Given this list of marker genes GPM6A, KRTAP13-2, ALDOC (NCBI Gene Id 230), FAM83H, HNRNPUL1, PRSS27, SRRM3, MNT, CEP95, EXOC5 (NCBI Gene Id 29024), RAVER1, TCERG1, PANX3, TFE3, MAG, GPRIN3, RAPGEFL1, QSOX1, SRSF6, LEP, NEUROG1, HOXA3, SPATA3, AMMECR1L, ERG, HOXA11, WNT10A, MDM4, NUDT4, SPAG9, DRG1, HNF4G, GON7, ZKSCAN8, DPP8, CELF2, CD40LG, TLN1, TOB1, KCNH2, GBX2, COL11A2, PCYT1B, FGF14 (fibroblast growth factor 14), HHEX, EFNA5, TFAP2E, ZNF276, RASAL2, CHGA, UBR7, SSC4D, YWHAE, LZTS2 (NCBI Gene Id 84445), KCNQ4, PAX6, SMAD6 (SMAD family member 6), SART1, MYH1, AP5M1, MOSPD1, PCGF2, TSSK2, DDX5, ANK3, COL11A1, ACY3, SELENOS, GADD45A, FBXL19, MAP2, DHRS11, ZNF654, HMGB1, RAB7A, ITGB4, ATG9A, PLXNB1, NFATC3, MYOZ2, PRKAG1, DIAPH1, SETD2, MIR17HG, CARMIL3, MAP4K5, RORB, TLX3, HPCA, POU4F3, SMTNL2, TSPAN17, MYF6, STC2 (NCBI Gene Id 8614), NXPH1, BCOR, HCN4, MORN1, FZD1, EIF4G2, TEKT5, ASIC5, FEZF2, JARID2, MPP3, FSBP, DNAJC14, HTR1B, LONRF3, TBC1D10B, HOXC4 (NCBI Gene Id 50712), RUNX1, HOXD10, TBX21, SHOX2, NLK, PNCK, ATP2B2, CHRFAM7A, USP2, ADAMTSL1, ABTB2, ANKZF1, REX1BD, RER1, SOBP, NRXN1, MACO1, HOXB5, LMO3, ZNF271P, CLN5, CREB3, ZNF423, HOXC6, AFF4, MYO18A, ZNF513, TENM1 (teneurin transmembrane protein 1), here is a description of the gene set: Human Gene Set: CATRRAGC_UNKNOWN studied in species Homo sapiens Genes having at least one occurrence of the highly conserved motif M134 CATRRAGC in the regions spanning 4 kb centered on their transcription starting sites. The motif does not match any known transcription factor binding site. from publication Xie X, Lu J, Kulbokas EJ, Golub TR, Mootha V, Lindblad-Toh K, Lander ES, Kellis M (PMID 15735639) Comprehensive identification of all functional elements encoded in the human genome is a fundamental need in biomedical research. Here, we present a comparative analysis of the human, mouse, rat and dog genomes to create a systematic catalogue of common regulatory motifs in promoters and 3' untranslated regions (3' UTRs). The promoter analysis yields 174 candidate motifs, including most previously known transcription-factor binding sites and 105 new motifs. The 3'-UTR analysis yields 106 motifs likely to be involved in post-transcriptional regulation. Nearly one-half are associated with microRNAs (miRNAs), leading to the discovery of many new miRNA genes and their likely target genes. Our results suggest that previous estimates of the number of human miRNA genes were low, and that miRNAs regulate at least 20% of human genes. The overall results provide a systematic view of gene regulation in the human, which will be refined as additional mammalian genomes become available.